The following is a description of a gene set: Binding to one of the p53 family of proteins. species: Homo sapiens Human Gene Set: GOMF_P53_BINDING, and this is the list of marker genes: PLK3, KDM8, RNF20, DUSP26, TAF1, CDKN2AIP, HIF1A, ARMC10, TAF3, DAXX, MAPKAPK5, TRIM29, RNF34, TP53BP2, EHMT1, EHMT2, CHD8, TP63, NOP53, STK11, RFFL, NTRK3, ANKRD1, NUAK1, TRIM24, TP73, GATA1, MDM2, MSX1, BLM (NCBI Gene Id 641), GSK3B, BCL2L12, HSPD1, PTTG1IP, RCHY1, DAZAP2, ZNF385A, CDKN2A, POU4F2, AXIN1, TRIAP1, USP10, PPP1R13B, TP53RK (NCBI Gene Id 112858), KDM1A, EP300, CDK5, SETD7, RFWD3, MUC1, USP7, SIRT1, TAF9, SMYD2, HDAC1, SMARCB1, BRCA1, TP53BP1, MUL1, BRD7, PSME3, TEP1, EEF2, BRD4, HTT, ZNF385B, SMARCA4, RNF125, CREBBP, PRMT5, TP53